Given this list of marker genes TRAF3, TMEM268, SUCO, TMEM185B, HIVEP1 (NCBI Gene Id 3096), NLE1 (notchless homolog 1), SLC25A28, NOP14-AS1, ZMPSTE24, SDC4, STAMBPL1, XPO4, REL, RCAN1, CD48, SNHG3, RRAD, VEGFA, SIK1, SEMA3D, HILPDA, SLC6A15, TOP1, NKX3-2 (NCBI Gene Id 579), ABCE1, PISD, CLDN16 (claudin 16), IPO4, BCL6, RIOX2 (NCBI Gene Id 84864), HIVEP3, ZNF778, ADGRB2, GNA14, GAR1 (NCBI Gene Id 54433), GEMIN4, MPHOSPH10, PPAT, COL6A3, PRPF39, ADAM22, PLK3, GNRHR, ZEB1, SLC12A8, PPP1R2, EIF2S1, MCAT, NCAN, ATXN2L, IRF8, RRP12, RSL1D1, IFNA2, SATB1, RPF1, POLR3C, RAN, METTL22, NXPH4, ADORA2B, CD44, PGAM1, EDNRB, EMC1, DDX3X, COPS2, NARS1, BLTP3B, HSPA9, AKAP1, PLAGL2, TNFRSF17, AIMP1, AGFG1, REV3L, SPATA2L, MAT2A, SMIM10L1, CCT2, DPH2, RARB, TNFAIP3, UAP1, LINC00115, RLIG1, BTG2, THAP12, PMAIP1, EID1, TOMM20, ICAM1, ZDHHC11, RGS2, MTHFD2, ZNF614, USP16, EXOSC4, BIN3, BZW2 (basic leucine zipper and W2 domains 2), MARCHF1, ILF2, TTC4, CLIC4, HK2, ALG3, EIF3D, PSMD12, PSMA2, CELA2A, NOC3L, SEC61G, NTN1, UQCRC2, CUL4A, ZC3H15, UCHL3, MPP1, TFAM, ECE1, TOX4, ARHGEF3, TASOR2, PAICS, SRPRB, FBL, GABPB1, CDK12, NDEL1, ILF3, KLHDC8A, LGALS14, WDR3, BCL9, EMCN, BIRC3, ATP6V0C, FSHR, GTF2F2, PRRX2, DDX24, MRPL4, MED28, NUP54 (NCBI Gene Id 53371), MAPKAPK5, ZNF593, TLE3, EIF5B, ZNF263, FKBP4, EIF3G, TRMT61B, CAMTA2, MYC, GRSF1, NELL1 (NCBI Gene Id 4745), ADAM9, OTUD4, SRP19, NRBF2, DIMT1, NT5DC3, RBM12, AKAP8, CXCL8, SETD4, VGLL1, AHNAK2, GPR137B, OSBPL3, MEX3C, DGKG, IDH3A, AHCTF1, NR3C1, FXN, NAT10, OPA1, SIAH2, CHSY1, CEBPZ, SRSF6, NT5E, CHUK, ODC1, H3-3B, MAPRE2, NABP1, PMPCA, TAF4B, MMS19, SLC29A3, MARCHF6, LANCL2, RPIA, LDHB, MYLIP, RRP15, TESK1, TIMM8A, here is a description of the gene set: species: Homo sapiens Expression profiling of Rag2-deficient Ets1++ and Rag2-deficient Ets1-- mature NK cells and WT bone marrow progenitors, WT T cells, and WT Pro B cells from publication Ramirez K, Chandler KJ, Spaulding C, Zandi S, Sigvardsson M, Graves BJ, Kee BL (PMID 22608498) Genes up-regulated in lymphoid primed multipotent progenitors versus granulocyte-monocyte progenitors. Human Gene Set: GSE37301_LYMPHOID_PRIMED_MPP_VS_GRAN_MONO_PROGENITOR_UP